The following is a description of a gene set: species: Mus musculus Mouse Gene Set: chr11B1, and this is the list of marker genes: Nt5m, Il5, Zfp354b, Vdac1, Gm12181, Gm24253, Gm12149, 2310058D17Rik, Slc36a1os, P4ha2, Nhp2, Prss38, Or9e1, Gm12163, Wnt9a, Gm25296, Btnl10, Or5af1, Trim17, Mir146, Gm12191, Gm12186, Gm12229, Irgm1, Mir7652, Rpl9-ps2, Mprip, Gm15755, Dppa1, Or2t49, Mir7671, Rufy1, Or2y1, Lypd8l, Or2w25, Ifi47, Zfp454, Gm22603, Or2v1, Mgat1, Cfap144, Irgm2, Thg1l, Fabp6, Mrpl55, Ebf1, Gm12250, Gm12261, Gfpt2, Sox30, Or2aa1, 9230009I02Rik, Rad50, Cdkl3, Acsl6, Flt4, Gdf9, Or2y10, Gm12219, Or2o1, Rack1, Zkscan17, Or2ak6, 4933405E24Rik, Or5af2, Gm12225, Irf1, Gm12247, Anxa6 (NCBI Gene Id 11749), Havcr1, Pld6, Or2y7 (olfactory receptor family 2 subfamily Y member 7), Mgat4b, Gm5027, Btnl9, Sh3bp5l, Or2y1c, Gm10435, Timd4, Clk4, Gm12185, 1700047K16Rik, Glra1, Rmnd5b, Gm12159, Gm12263, Gm11189, Il4, Jade2, A430108G06Rik, Gm25930, Or1ad5-ps1, Adamts2, Mir340, 9530068E07Rik, G3bp1, Hnrnph1 (NCBI Gene Id 59013), Gm12152, Or11l3, Gm12192, Gm16170, Hnrnpab, Gm26061, Gm12198, Nlrp3, Wnt3a, Gm12238, 1700007J10Rik, Gm12183, Gpx3, Or2y8, D930048N14Rik (RIKEN cDNA D930048N14 gene), Garin3, Rnf145, Rapgef6, Or2y1g (NCBI Gene Id 258463), Or2y16, Larp1, Mup-ps22, Or1ad7-ps1, Gm12203, Or2t50-ps1 (olfactory receptor family 2 subfamily T member 50, pseudogene 1), Snord96a, Trim58, Gm24582, Obscn, Mrpl22, Sparc, Gm12661, Gm12242, 9930111J21Rik2, Timd7-ps, Ube2b, H2bc27, Or2t26, Or2t47, Gria1, Igtp, Gjc2, Gm9837, Ttc1, Kif3a, Gm12226, Platr20, Rai1, Itk, Sqstm1, Gm12190, Il12b, Pdlim4, Csf2, Or2t45, Rpl9-ps3, Septin8, Gm12264, Gm12199, Fstl4, Cdk2ap1rt, Gm5431, Or2v2, Sft2d1rt, Or2t48, Guk1 (guanylate kinase 1), Gm12153, Rps2-ps4, Or2y13, Cyfip2, Or2ak4, 4933426K07Rik, Fndc9, Snord95, Gm12194, A630014C17Rik, Gm24422, Canx, Sar1b, Phykpl, Gm12224, Jmjd4, Fnip1, Sec24a, Gm12245, Or2y12, Il13, Or2y17, Havcr2, Lyrm7, 9930111J21Rik1, Trim11, Sgcd, Or2z2, Mir804, Sap30l, Gm12240, Gm12257, Med9, 2610507I01Rik, Gm12189, Mir8100, Galnt10, Trappc2b, Or2w3, Prop1, Or2ak5, Gm12161, Atox1, Gm22284, Gm12176, H3f4, Skp1, Trim41, Arf1, Cops3, Tcf7, Gm12171, Slc22a5, Gm12220, Gm12570, Msantd5l, Lyrm7os, Ublcp1, Gm12202, Pemt, Gm2a, Or2av9, Gm12230, Gm12253, Or2t44, Gm12218, Grm6, Zfp867, N4bp3, Gemin5, Iba57, Gm12151, Gm12179, Mir6919, Gm12196, Or2y1b, Aff4, Timd5, Uqcrq, Or2y6, Gm12236, Zfp692, Lsm11, Gm39822, Flcn, Hand1, Gm12156, Nipal4, Gm12174, Rnf130, Or2t46, Adam19 (ADAM metallopeptidase domain 19), Slc36a3os, Or1ad1, Or2w3b, Ccnjl, Or2t29, 4933414I15Rik, Cdkn2aipnl, Gm12244, Slc36a2, Gm23039, Ltc4s, Or2y11, Or2y1f, 4933424L21Rik, Gm12165 (NCBI Gene Id 667037), Or1x2, Gm12241, Gm24198, Gm12206, Mapk9, Gm12258, Meikin, Gm12188, Tgtp2, Col23a1, 2010001A14Rik, Gm12222, 1810065E05Rik, Gm12210, Ccdc69, Msantd5, Or2ak7, Zcchc10, Or2y15, Gm12568, Or2y1e, Gm12164, Or2b11, Gm12201, Mfap3, Gm16062, Pttg1, Or2av10-ps1, Gm12187, Tgtp1, Med9os, Fat2, Med7, Zfp62, Or2t43, C1qtnf2, 1810063I02Rik, Gm12180, Slc22a4, Sowaha, Slc22a21, Gm12217, Gm12221, Gm12216, Gm12182, Mir3061, Fam114a2, Trim7, Timd6, Atp5pb-ps, Gm11186, Zfp879, Zfp354a, Rnf187, Gm12167, Snap47, Cnot6 (CCR4-NOT transcription complex, subunit 6), Shroom1, Gm12235, 4930438A08Rik, Psme2b, Slc36a1, Pwwp2a, Or2y9-ps1, Mir7239, Gm12193, Nmur2, Cdc42se2, Tnip1, 4933439C10Rik, Cnot8, Gm12239, Rasd1, Scgb3a1, Slu7, H2bc26, Or2ab1, F630206G17Rik, Hint1, Slc36a3, Gm12168, Timd2, Cby3, Gm9945, Or1ad6, Gm12227, Clint1, Lypd8, Gm5038, Leap2, Il3, Or2y14 (NCBI Gene Id 258464), Tbc1d9b, H2ac25, Zfp672, Faxdc2, Mrnip, Hspa4, Lypd9, Zfp39, Rasgef1c, Mir6920, Maml1, Ppp2ca, Or1x6, 2810021J22Rik, 4933415A04Rik, Or1ad8, Zfp2, Gm12251, Or2y1d, Adra1b, 2310033P09Rik, Zfp354c (NCBI Gene Id 319696), 4930597A21Rik, Gm12209